The following is a description of a gene set: studied in species Homo sapiens Any process that stops, prevents, or reduces the frequency, rate or extent of signal transduction mediated by the JNK cascade. Human Gene Set: GOBP_NEGATIVE_REGULATION_OF_JNK_CASCADE, and this is the list of marker genes: PDCD4, SIRPA, ITCH, DACT1, DUSP19, CYLD, MARVELD3, DNAJA1, KLHL31, NCOR1, F2RL1, MEN1, PRKN, DUSP3 (dual specificity phosphatase 3), ZNF675, PAFAH1B1, PER1, PRMT1, MIR92A1, PINK1, AMBP, MAPK8IP1, HIPK3, SERPINB3 (serpin family B member 3), AIDA (NCBI Gene Id 92615), FKTN, NPPA, RGS2, GSTP1, SH3RF2 (SH3 domain containing ring finger 2), TAOK3, TRIB1, DUSP10, HDAC3, MECOM, ZMYND11, GPS2, PTPN22